The following is a description of a gene set: studied in species Homo sapiens Compensating for the two-fold variation in X-chromosome:autosome ratios between sexes by a global inactivation of all, or most of, the genes on either the paternal or maternal X-chromosome in the XX sex. Human Gene Set: GOBP_RANDOM_INACTIVATION_OF_X_CHROMOSOME, and this is the list of marker genes: LBR, HDAC3, CIZ1, PCGF3, RLIM, HNRNPU, XIST, SUZ12, SPEN, BRCA1, PCGF5, HNRNPK, CDYL, JARID2